Given this list of marker genes Lin7b, Dlg1, Mpp7, Lin7c, Lin7a, here is a description of the gene set: species: Mus musculus A heterotrimeric protein complex formed by the association of MMP7, DLG1 and either LIN7A or LIN7C; regulates the stability and localization of DLG1 to cell junctions. Mouse Gene Set: GOCC_MPP7_DLG1_LIN7_COMPLEX